The following is a description of a gene set: studied in species Mus musculus Mouse Gene Set: GOBP_GALACTOSE_CATABOLIC_PROCESS_VIA_UDP_GALACTOSE_LELOIR_PATHWAY The chemical reactions and pathways resulting in the breakdown of galactose, via the intermediate UDP-galactose., and this is the list of marker genes: Galm, Galt, Pgm1, Gale, Galk1